The following is a description of a gene set: species: Homo sapiens from publication He P, Lim K, Sun D, Pett JP, Jeng Q, Polanski K, Dong Z, Bolt L, Richardson L, Mamanova L, Dabrowska M, Wilbrey-Clark A, Madissoon E, Tuong ZK, Dann E, Suo C, Goh I, Yoshida M, Nikolić MZ, Janes SM, He X, Barker RA, Teichmann SA, Marioni JC, Meyer KB, Rawlins EL (PMID 36493756) Human Gene Set: HE_LIM_SUN_FETAL_LUNG_C1_LATE_AIRWAY_PROGENITOR_CELL Late airway progenitor, and this is the list of marker genes: CYTL1, LMO3, ICAM1, PCP4, LINC03007, CAPS, ANXA1, NTN1, NCKAP5, CFH, SULT2B1, PCDH7 (NCBI Gene Id 90855), AGR3, CRTAC1 (cartilage acidic protein 1), BANCR, AQP5-AS1, RP1, RAB27B, CFHR1, LURAP1L (NCBI Gene Id 286343), ARSJ, CLIC5, ANTXR2, GAS6, LIPH, AQP5, ICAM4